Given this list of marker genes KCNB1, SYT4, P2RX7, AVP, CHRNB2, RAB3GAP1, SLC17A8, DRD2, ABAT, SLC7A5, PSEN1, DTNBP1, RAB3B, ADORA2A (adenosine A2a receptor), ITGB1, OXT (oxytocin/neurophysin I prepropeptide), KMO, SYT1, OPRK1, STX1A, NTSR1, AVPR1A, CLTRN (NCBI Gene Id 57393), GABBR1, STXBP1, TRH, SLC12A2, DRD4, ACE2, NPY2R (neuropeptide Y receptor Y2), SLC18A3, PINK1, ARL6IP1 (ADP ribosylation factor like GTPase 6 interacting protein 1), TACR2, CARTPT, GDNF, CXCL12, SLC38A3, GRK2, here is a description of the gene set: species: Homo sapiens Any process that activates, maintains or increases the frequency, rate or extent of the directed movement of amines into, out of or within a cell, or between cells, by means of some agent such as a transporter or pore. Human Gene Set: GOBP_POSITIVE_REGULATION_OF_AMINE_TRANSPORT